Given this list of marker genes APPL2, SLC52A3, ERO1A, COMT, PLIN1, EIF2B4, VCP, KCNK4, SCARA5, ATXN3, DISC1, EIF2B5, ZNF516, TFEC, MAP2K7, TCIM, HSP90AB2P, OPN4, EIF2AK3, DRGX, NOS3, FOXO1, CIDEA, HSP90AB3P, HTRA2, TMEM135, ACADM, HDAC6, CDH8, PCSK1N, HPCAL4, TPR, HSPA2, TAC4, IER5, CRYAB, ATM, CRYAA, TRPM2, EIF2AK4, RBBP7 (RB binding protein 7, chromatin remodeling factor), IRAK1, EIF2S1, CXCL10, TRPA1, SLC25A27, EIF2B2, IGF1, BAG3, HSF1, SCN9A, HSPA1A, FGF16, SAXO1, GSK3B, MMP24, UCP2, NR2F6, ANO1, NF1, MAPT, ADORA1, EP300, NFE2L1, ANO3, LRP11, HSBP1L1, ADRB3, EIF2B1, DNAJC2, CLPB, NTSR1, CETN1, NFKBIA, PDCD6, PSIP1 (NCBI Gene Id 93428), LYN, NGFR, RNF170, LXN, SLC27A1, ADRB2, ATR, HSPB1, CREBBP, TRPV3, ALDH18A1, EPHB1, CXCL12, CASQ1, HSPB2, UCP3, GLRX2, VGF, PRKACA, HDAC2, NOS1 (nitric oxide synthase 1), GRIK2, SCN2B, THBS1, SLU7, DNAJC3, SLC12A5, HMGCS2, DNAJA1, ASIC3, DNAJB6, METRNL, IL1A, ADRB1, MICA (MHC class I polypeptide-related sequence A), SIRT1, MICB, DNAJA4, SCRN3, AKT1, DNAJA2, GCLC, PIRT, HSBP1, HSP90AB4P, HMOX1, HSPA1B, HSPB6, P2RX3, SOD1, TRPV2, HSP90AA1, HSPA6, DNAJA3, TRPV4, FGF1 (NCBI Gene Id 29961), YWHAE, DHX36, LIPA, CHORDC1, CRNN, EIF2B3, CIRBP, STUB1, HIKESHI (NCBI Gene Id 51511), TRPM8, TP53INP1, DAXX, GMPR, PRKAA1, NTRK1, THRA, ST8SIA1, HSP90AB1, SUMO1, MTOR, HSPD1, ACADVL, ZFAND1, UCP1, ACOT11 (NCBI Gene Id 91515), HTR2A, EEF1D, SCN11A, RNF34, WDR47, TRPV1, PLAC8, DNAJB1, PRDM12, DNAJC7, SLC9A1, STAC, MAPKAPK2, DNAJB4, RHO, HSP90AA2P, TOP1, TAC1, here is a description of the gene set: Human Gene Set: GOBP_RESPONSE_TO_TEMPERATURE_STIMULUS Any process that results in a change in state or activity of a cell or an organism (in terms of movement, secretion, enzyme production, gene expression, etc.) as a result of a temperature stimulus. studied in species Homo sapiens